Given this list of marker genes PGAP1 (NCBI Gene Id 80055), ANO3, LIG1, CD70, TNFSF9, JADE3, BBS4, SEC61A1, CCNG1, APOBEC3C, ADCY1, CCP110, RALGDS, TNFSF4, XPC, SLC7A6, MAD1L1, GAMT, ITM2B, LAMP3 (NCBI Gene Id 27074), PGF, DSE, CLK4, KCNN3, RABGGTA, PLXNB2, TMEM168 (NCBI Gene Id 64418), SLC35E3, CHMP3, TP53TG1, ZP3, PODXL, WRAP73, RNF19B, ZBED1, AAK1, PPM1D, CCDC90B (coiled-coil domain containing 90B), PROCR, FEZ1, TENT5A, MYBL1, PSEN2, FGF2, NOTCH1, LDLRAD4, PRKAB1 (protein kinase AMP-activated non-catalytic subunit beta 1), NOPCHAP1, MOSPD1, SLC35D1, ZBTB20 (NCBI Gene Id 26137), RAD51C, ZNF79, SESN1, APOBEC3B, PLK2, ANKRA2, FBXW7, TMT1A, CYP4F3, NHLH2, DDR1, INPP1, TNFRSF10B, NINJ1, GLS2, FAS, SOCS1, CLK1, TAX1BP3, SPARC, ORAI3, GCH1, FZD6, GADD45A, MR1, SOCS2, PBLD, BTG2, ZMAT3, MRPL49, CLP1, NABP1, APAF1, ABCA12, RAB1A, SLC30A1, MLF2, CCSER2, CROT, IER3, TRAF4, TIGAR, DNAJB4, FOSL1, DRAM1, GNB2, RAP2B, CDC42, APOBEC3G, MYH10, MICALL1, MT1X, GDF15, INKA2, SAC3D1, RRAD, PHLDA3, SMAD5, CDC42EP4, FAM169A, RAB23, DDIT3, MAP4K4, NUDT15, ITPKC, POLH, ZNF195, TRIM23, MDM2, RETSAT, RXRA, SDC1, FDXR, CEACAM1, C11orf24 (NCBI Gene Id 53838), CLGN, TP53I3, CSF1, CDIP1, HRAS, MACO1, EI24, LMNA, PSTPIP2, BBC3, CGRRF1, FHL2, ITM2A, MT1F, ATF3, ID3, DDB2, TM7SF3, ACTA2, RGS16, F2R, DUSP14, ZNF654, FUCA1, TRIAP1, HCAR3, TRIM32, APTX, STX6, RFX7, ZNF623, PMAIP1, DLG5, CES2, TOB1, IGHV4-61, AEN, MT1H, ASTN2, PDE4B, PIDD1, CDKN1A, here is a description of the gene set: species: Homo sapiens Genes up-regulated in B lymphocytes at 6 h after exprosure to 10 Gy dose of ionizing radiation. Radiation exposure through environmental, medical, and occupational settings is increasingly common. While radiation has harmful effects, it has utility in many applications such as radiotherapy for cancer. To increase the efficacy of radiation treatment and minimize its risks, a better understanding of the individual differences in radiosensitivity and the molecular basis of radiation response is needed. Here, we integrated human genetic and functional genomic approaches to study the response of human cells to radiation. We measured radiation-induced changes in gene expression and cell death in B cells from normal individuals. We found extensive individual variation in gene expression and cellular responses. To understand the genetic basis of this variation, we mapped the DNA sequence variants that influence expression response to radiation. We also identified radiation-responsive genes that regulate cell death; silencing of these genes by small interfering RNA led to an increase in radiation-induced cell death in human B cells, colorectal and prostate cancer cells. Together these results uncovered DNA variants that contribute to radiosensitivity and identified genes that can be targeted to increase the sensitivity of tumors to radiation. Human Gene Set: SMIRNOV_RESPONSE_TO_IR_6HR_UP from publication Smirnov DA, Brady L, Halasa K, Morley M, Solomon S, Cheung VG (PMID 21844125)